The following is a description of a gene set: A process of protein insertion into the endoplasmic reticulum (ER) membrane in which a tail-anchored (TA) transmembrane protein is incorporated into an endoplasmic reticulum (ER) membrane. TA transmembrane protein, also named type II transmembrane proteins, contain a single C- terminal transmembrane region. Human Gene Set: GOBP_TAIL_ANCHORED_MEMBRANE_PROTEIN_INSERTION_INTO_ER_MEMBRANE studied in species Homo sapiens, and this is the list of marker genes: GET3, EMC10, EMC8, EMC4, BAG6, EMC7, EMC1, GET1, EMC9, CAMLG, SGTA, GET4, MMGT1, UBL4A, EMC3, EMC2, EMC6